The following is a description of a gene set: Binding to an insulin-like growth factor receptor. studied in species Mus musculus Mouse Gene Set: GOMF_INSULIN_LIKE_GROWTH_FACTOR_RECEPTOR_BINDING, and this is the list of marker genes: Ren1, Ins1, Ywhag, Ins2 (NCBI Gene Id 16334), Pik3r1, Socs2, Gnas, Irs1, Igf2, Insr, Socs1, Creg1, Igf1, Shc1, Arrb1, Crk